The following is a description of a gene set: Human Gene Set: GOBP_GLYCOSYL_COMPOUND_CATABOLIC_PROCESS The chemical reactions and pathways resulting in the breakdown of glycosyl compound. studied in species Homo sapiens, and this is the list of marker genes: GBA2, FUCA2, UPP2, XDH, GLA (galactosidase alpha), NUDT1, NAGA, ENPP4, DERA, ADA2, GBA3, CDA, AICDA, FUCA1, MTAP, GDA, GBA1, DPYD, MAPDA, DCTD, APOBEC3G, UPP1, UPB1, ADA, CDADC1, PNP, APOBEC3C